Given this list of marker genes DMTN, AQP1, PAK1, BAG4, THBS1, MIR145, ITGB1, AKT1, PRKCE, DDR2, PTK2, AKAP12, TGFB1 (NCBI Gene Id 7040), ACTA2, ITGB3, ARHGEF7, here is a description of the gene set: Any process that increases the rate, frequency or extent of fibroblast cell migration. Fibroblast cell migration is accomplished by extension and retraction of a pseudopodium. species: Homo sapiens Human Gene Set: GOBP_POSITIVE_REGULATION_OF_FIBROBLAST_MIGRATION